The following is a description of a gene set: species: Mus musculus Mouse Gene Set: GOBP_INHIBITORY_POSTSYNAPTIC_POTENTIAL A process that causes a temporary decrease in postsynaptic membrane potential due to the flow of negatively charged ions into the postsynaptic cell. The flow of ions that causes an IPSP is an inhibitory postsynaptic current (IPSC) and makes it more difficult for the neuron to fire an action potential., and this is the list of marker genes: Grin2a, Adora2a, Gabrb3, Rims1, Drd4, Insyn1, Cx3cl1, Nlgn3, Npas4, Nlgn2, Grik1, Chrna2, Rims2, Adrb1, Bdnf, Insyn2a, Ntsr1, Dbn1, Unc13b, Abat, Igsf9b, Glra1, Nlgn1, Grik2, Grin2b, Chrna4